The following is a description of a gene set: Mouse Gene Set: GOBP_REGULATION_OF_L_GLUTAMATE_IMPORT_ACROSS_PLASMA_MEMBRANE Any process that modulates the frequency, rate or extent of L-glutamate import into a cell. studied in species Mus musculus, and this is the list of marker genes: Psen1, Septin2, Arl6ip1, Itgb1 (integrin beta 1 (fibronectin receptor beta)), Slc17a8, Arl6ip5, Per2, Arhgef11, Tnf (NCBI Gene Id 21926)